The following is a description of a gene set: studied in species Homo sapiens AMPA receptors are functionally either Ca permeable or Ca impermeable based on the subunit composition. Ca permeability is determined by GluR2 subunit which undergoes post-transcriptional RNA editing that changes glutamine (Q) at the pore to arginine (R). Incorporation of even a single subunit in the AMPA receptor confers Ca-limiting properties. Ca permeable AMPA receptors permit Ca and Na whereas Ca impermeable AMPA receptors permit only Na. In general, glutamatergic neurons contain Ca impermeable AMPA receptors and GABAergic interneurons contain Ca permeable AMPA receptors. However, some synapses do contain a mixture of Ca permeable and Ca impermeable AMPA receptors. GluR1-4 are encoded by four genes however, alternative splicing generates several functional subunits namely long and short forms of GluR1 and GluR2. GluR4 has long tail only and GluR3 has short tail only. Besides the differences in the tail length, flip/flop isoforms are generated by an interchangeable exon that codes the fourth membranous domain towards the C terminus. The fip/flop isoforms determine rate of desensitization/resensitization and the rate of channel closing. Receptors homomers or heteromers assembled from the combination of GluR1-4 subunits that vary in C tail length and flip/flop versions generates a whole battery of functionally distinct AMPA receptors. part of: Glutamate binding, activation of AMPA receptors and synaptic plasticity Reactome Pathway: Activation of AMPA receptors, and this is the list of marker genes: GRIA1, GRIA4, GRIA3, GRIA2